The following is a description of a gene set: Myoclonic status epilepticus A type of motor status epilepticus with repeating bilateral sudden brief (less than 100 ms) involuntary single or multiple contraction of muscles or muscle groups of variable topography. studied in species Homo sapiens Human Gene Set: HP_MYOCLONIC_STATUS_EPILEPTICUS, and this is the list of marker genes: ASAH1 (N-acylsphingosine amidohydrolase 1), GOSR2, FBXO28 (NCBI Gene Id 23219), KCTD7, SLC1A2